Given this list of marker genes TBX19, NEUROD1, GCK, ABCC8, DBH, KDM6A, FBP1, COX10, HSD3B2, CLPB, PAX4, NSD1, HNF4A, IGF2, CYP11A1, KCNJ11, WARS2, HERC1, INS, MADD, SLC25A20, H19, MYT1L, GYS2, HADH, BLK, KCNQ1OT1, HNF1A, CIC, MTOR, EBP, CDKN1C, MSL3, PROP1, DNAJC19, APC2, OTX2, PET100, AKT2, PRKAG2, PDX1, GFM2, HTRA2 (HtrA serine peptidase 2), YARS1, KCNQ1, CEL, KLF11 (NCBI Gene Id 8462), POLR1A, APPL1, here is a description of the gene set: Neonatal hypoglycemia Human Gene Set: HP_NEONATAL_HYPOGLYCEMIA species: Homo sapiens